Given this list of marker genes B3gat3, Ust, Idua, Chst14, Csgalnact2, Chst12, Hexb, Ids, B3galt6, Hexa, Dsel, Dse, Arsb, here is a description of the gene set: Mouse Gene Set: GOBP_DERMATAN_SULFATE_PROTEOGLYCAN_METABOLIC_PROCESS The chemical reactions and pathways involving dermatan sulfate proteoglycans, which consist of a core protein linked to a dermatan sulfate glycosaminoglycan. The dermatan sulfate chain is composed of the repeating disaccharide unit beta-(1,4)-D-hexuronic acid-beta-(1,3)-N-acetyl-D-galactosamine. The former can be a mixture of sulfated and nonsulfated D-glucuronic and L-iduronic acids, and the latter can be O-sulfated. species: Mus musculus